The following is a description of a gene set: species: Homo sapiens from publication Schaefer CF, Anthony K, Krupa S, Buchoff J, Day M, Hannay T, Buetow KH (PMID 18832364) Human Gene Set: PID_WNT_NONCANONICAL_PATHWAY Noncanonical Wnt signaling pathway, and this is the list of marker genes: MAPK10, MAP3K7, RHOA, YES1, CHD7, SETDB1, CSNK1A1, ROCK1, CTHRC1, NLK, DVL1, MAPK8, WNT5A, CDC42, PPARG, FLNA, CAMK2A, PRKCZ, TAB2, ARRB2, MAPK9, DAAM1, TAB1, ROR2, FZD5, RAC1, NFATC2, FZD2, DVL3, FZD7, DVL2, FZD6